The following is a description of a gene set: Human Gene Set: HP_BCGITIS BCGitis Local or regional infection with Bacillus Calmette-Guerin (BCG) following vaccination. studied in species Homo sapiens, and this is the list of marker genes: IL12B, DOCK11, MAP3K14, STAT1, MCTS1, FCGR3A, RFX5, ISG15, ORAI1, IRF8, SPPL2A, DCLRE1C, IRF1, IFNG